Given this list of marker genes Barx2, Egr1, Ddx5, Rbfox1, Klhl40, Mir669a-6, Rbm24, Mir669a-7, Ankrd2, Ankrd1, Mir669a-9, Foxn2, Lemd2, Mir669a-2, Fos, Ddx17, Large1, Tbx1, Btg2, Bmal1, Eomes, Nupr1, Six1, Sox8, Cyp26b1, Maff, Mir669a-5, Bcl9l, Mef2d, Mylk2, Hivep3, Mir669a-1, Hlf (NCBI Gene Id 217082), Hdac5, Uqcc2, Nr4a1, Ephb1, Myocd, Egr2, Nfix, Megf10, Myf6, Shh, Emd, Gm34220, Hdac9, Scx, Mstn, Gtf3c5, Rb1 (NCBI Gene Id 19645), B4galnt2, Notch1, Ppif (NCBI Gene Id 105675), Mir669a-4, Mef2c (myocyte enhancer factor 2C), Atf3, Plagl1, Cited2, Bcl9, Pax5, Pax3, Lemd3, Akirin1, Nln, Klhl41, Myog (myogenin), Gata4, Dmrta2, Myc, Mir669a-3, Six4, Kras, Gpc1, Cops2, Mcub, Phox2b, Med20, Smyd1, Asb2, Vax1, Mir669a-10, Cdon (cell adhesion molecule-related/down-regulated by oncogenes), Myf5, S100b, Fkrp, Ankrd33, Snhg15, Pax7, Zfp689, Mir675, Hdac4, Hmg20b, Nr1d2, Fktn, Snw1, Klf5, Myod1 (myogenic differentiation 1), Heyl, Mir669a-8, Selenon, Kat8, Wnt3a, Col6a1, Sox11, Sap30, here is a description of the gene set: Mouse Gene Set: GOBP_SKELETAL_MUSCLE_CELL_DIFFERENTIATION species: Mus musculus The process in which a relatively unspecialized cell acquires specialized features of a skeletal muscle cell, a somatic cell located in skeletal muscle.